The following is a description of a gene set: Abnormal decrease of absolute number of eosinophils in the blood, per microlitre, compared to a reference range for a given sex and age-group. species: Homo sapiens Human Gene Set: HP_DECREASED_TOTAL_EOSINOPHIL_COUNT Decreased total eosinophil count, and this is the list of marker genes: BRAF, USP8, ATRX, TP53, CDH23, NR3C1, ELANE, CARD10, USP48